The following is a description of a gene set: studied in species Homo sapiens Human Gene Set: WP_ROLES_OF_CERAMIDES_IN_DEVELOPMENT_OF_INSULIN_RESISTANCE Roles of ceramides in development of insulin resistance, and this is the list of marker genes: MAPK8, PDX1, SMPD3, IRS1, TNF, PPP2CA, PRKCZ, PRKAG3, TRAF1, AKT1, ERN1, INS, RPS6KB1, MAFA, ACSL1, CPT1B, IRS2, SLC2A4, TNFRSF1A, CD36, INSR (NCBI Gene Id 3643), PIK3R1 (NCBI Gene Id 5295, phosphoinositide-3-kinase regulatory subunit 1), EIF2AK2